The following is a description of a gene set: studied in species Mus musculus Mouse Gene Set: chr7B4, and this is the list of marker genes: Gm21034 (NCBI Gene Id 638046), Gm21032, E2f8, 4933405O20Rik, Slc17a6, Nell1os, Slc6a5, Mrgprc7-ps, Mrgpra4, Gm21037, Gm9354, Zdhhc13, Gm18352, Fancf, Gm5734, Mrgprb11-ps, Mir6238, Gm9357, Ano5 (NCBI Gene Id 233246), Mrgprx1, Mrgprb4, Gm18353 (NCBI Gene Id 100416995), Mrgpra18-ps, Gm18350, Gm18348, Mrgprb7-ps, Gm7336, Mrgprc2-ps, Mrgprb13, Mrgprb9-ps, Gm18356, Gm20074, Gm22444, Gm18351, Csrp3, Mrgprb2, Gm45086, Gm42402 (NCBI Gene Id 630820), Mrgprb8, Gm6181, Gm2707, Gm9343, Mrgprb3, Ccdc179, Gm16478, Dbx1, Mrgprb12-ps, Gm21036, Svip, Gm5733, Htatip2, Gm18357, Nav2, 9130015G15Rik, Gm21033, Gas2, Nell1, Mrgprx2, Gm18559, Mrgprc3-ps, Gm2788, Mrgprb1 (NCBI Gene Id 233231), Mrgprb5, Gm18349, Prmt3, Gm21035, Gm32849